The following is a description of a gene set: Reactome Pathway: Gap junction assembly species: Mus musculus electronically inferred by orthology from the curated human pathway This event has been computationally inferred from an event that has been demonstrated in another species.<p>The inference is based on the homology mapping from PANTHER. Briefly, reactions for which all involved PhysicalEntities (in input, output and catalyst) have a mapped orthologue/paralogue (for complexes at least 75% of components must have a mapping) are inferred to the other species. part of: Gap junction trafficking, and this is the list of marker genes: Gjb2, Tubb4b, Tubb2b, Tuba3b, Tubb6, Gjd3, Gja4, Gjb5, Tuba8, Tuba1b, Gjd2, Tubb4a, Tuba1c, Tubal3, Tuba4a, Gja3, Tuba1a, Gja1, Gjb4 (gap junction protein, beta 4)